The following is a description of a gene set: Human Gene Set: GOBP_RESPONSE_TO_MISFOLDED_PROTEIN Any process that results in a change in state or activity of a cell or an organism (in terms of movement, secretion, enzyme production, gene expression, etc.) as a result of a misfolded protein stimulus. studied in species Homo sapiens, and this is the list of marker genes: UBR5, F12, UFD1, DNAJC18, UBR4 (ubiquitin protein ligase E3 component n-recognin 4), HDAC6, SDF2L1, STUB1, ATXN3, DERL1, DNAJB14, VCP, CUL3, RNF126, UBE2W (NCBI Gene Id 55284), AKIRIN2, DNAJB12, KLHL15, CAV1, CLU